The following is a description of a gene set: Catalysis of the reaction: a sterol ester + H2O = a fatty acid + a sterol + H+. species: Homo sapiens Human Gene Set: GOMF_STEROL_ESTER_ESTERASE_ACTIVITY, and this is the list of marker genes: LIPN, LIPE, LDAH, CES1, LCAT, NCEH1, CEL, LIPA